The following is a description of a gene set: Catalysis of the ligation of an acid to an amino acid via a carbon-nitrogen bond, with the concomitant hydrolysis of the diphosphate bond in ATP or a similar triphosphate. Mouse Gene Set: GOMF_ACID_AMINO_ACID_LIGASE_ACTIVITY studied in species Mus musculus, and this is the list of marker genes: Fpgs, Ttll7, Ttll10, Ttl, Ttll8, Ttll6, Ttll12, Gss, Ttll9, Ttll2, Ttll4, Ttll11, Ttll3, Paics, Gclc, Gclm, Ttll1, Tpgs1, Ghdc, Ttll5, Carns1, Ttll13, Ppcs